The following is a description of a gene set: Mouse Gene Set: GOMF_OXYGEN_BINDING Binding to oxygen (O2). species: Mus musculus, and this is the list of marker genes: Tdo2, Hbb-bh1, Hbq1b, Hba-a1 (hemoglobin alpha, adult chain 1), Alb, Cyp2f2, Hbb-bt, Hba-x, Haao, Hbq1a, Adgb, Ido1, Th, Hbb-bh0, Hbb-bh2 (NCBI Gene Id 633175), Hbb-y, Cbs, Hbb-bs, Sod2, Cygb, Ngb, Mb